Given this list of marker genes KIAA1958, AFDN, CREBRF (CREB3 regulatory factor), BMP3, RBMS1, CFTR, SEMA3A, PEX5L, MAP1B, NFIB, GPR12, SLC30A7, CACNA1C, TUBB1, SLC26A3, RAD23B, RAB27B, SEC24A, ANKMY2, RAB3C, MSI2, ZC3H6, ZFHX3, PROS1 (NCBI Gene Id 5627), PNISR, MGAT4A, TACC2, AKAP17A, SHMT1, MED1, SGIP1, TENM1, MYCT1, TMCC2, CDKL2, CSE1L, URI1, SLC1A2, TBCA, PCDH10, CEP120, CXXC4, KIAA2013, TNPO3 (NCBI Gene Id 404679), SYDE2, SLC17A7, CPLX3 (NCBI Gene Id 594855), BRCA2, DPM1, USP51, TNFSF10 (TNF superfamily member 10), CA10, MZT1, C21orf91, UBE2L6 (NCBI Gene Id 9246), TMEM154, LIN54, UTP15, SYT16, CEP170, PAG1, LATS2, VCPIP1, BCL7B, RAB23, OSR2, ASXL3, U2SURP, SP100, ZNF711, ZBTB21, USP24, TAF4B, FZD3, ABI3BP, CFHR3, CEBPZOS (NCBI Gene Id 105374463), TCF21, CHL1, CRIPT, SRP72, CELF1, TRAF3, CEP97, TOR1AIP2, DENND6A, SENP3, MEIS2, TRIM15, TUT7, SCG3, RUBCNL, SPOPL, SGMS1, RABEP1, SNAP91, EEF2K (NCBI Gene Id 29904), RPS6KA6, DNAJC6, ZYG11B, ZDHHC21, WDR26, PCDH19, NAV1, ELL2 (elongation factor for RNA polymerase II 2), CPT1A, UBE2B, SMN2, SMAD1, ZNF772, PIM1, FBXW11, RAPGEF5, C17orf100, MAF, SNW1, PPP1R9A, TRHDE, PDIK1L, ANKRD40, ABHD18, CXCR5 (NCBI Gene Id 643), STXBP5L, TLR6, SLC22A17, DSG2, ONECUT2, NAV3, PRRC2B, ITPR1, HLA-DQA1, WDR35, ENOPH1, RBM47, LMAN2, APBB2, PLOD2, SEPTIN9, SCAI, CSRNP3, PTPN4, CCDC82, DPYSL2, LAMC2, MBNL3, AAK1, GPATCH2L, ANKRD22, C3orf70, MIER3, ASB7, C7orf57, PTP4A1, NMNAT2, ZNF280C, SERPINE1, SEC62, FOXN2, KIF13A, TMTC3, VGLL3, STRIP2, VWC2, PELI1, PDS5A, ZFHX4, KIF4A, EFNB2, SLC4A4, ARF6, CADM1, MET, KPNA6, TIA1, RIF1, POU4F1, MED14, CAV2, PHACTR2, PPM1E, SEC63, RABGAP1L, LRCH2, CHD9, RBMS3, DDX3X, CLTA, MBNL2 (muscleblind like splicing regulator 2), ESM1, DYNC1I1, KALRN, TMEM59, MATR3, FAM169A, WDR48, MCTS1, GNPNAT1, PDX1, NCOA2, TTC39C, ARHGAP6, PLSCR5, EPHA3, ELF2, TMEM26 (transmembrane protein 26, NCBI Gene Id 219623), PAXBP1, APC, CCT4, BBOX1, EIF5, ZNF148, RB1, SLC35F1, ABCC12, NPL, CNOT6, EPHA5, STAM, CREB1, AGO4, RPS6KB1, SAMTOR, PHC3, KCNAB1, LCOR, GATA3, LHFPL3, RB1CC1, DCUN1D1, SLC46A3, JAKMIP2, SRD5A2, ZBTB20, XRN1 (5'-3' exoribonuclease 1), NRP1, ZMYM3, PRKACB, PPP1CC, PPARGC1A, ZNF652, BCL2L11, HDAC9, NEXMIF, MAP3K1, OLFML1, DCBLD2, CYSTM1, SREK1, SLC16A12, CALCB, TMEM132B, LGALSL, MAPK9, CCNG2, RORA, C15orf40, OLFM3, KIF18A, RBM42, LRRC4C, KDM4C, CH25H, NMT2, CLDN11, LRRTM3, SOCS6, KIF3A, MORF4L2, XIAP, CLINT1, TMOD1 (tropomodulin 1), EML6, TPR, ERBIN, PANK1, FHOD3, ELOVL7, MAB21L1, PCDH15, PIANP, FAM135A, BMP2K, NAP1L2, FTSJ1, THSD7A, PHYHIPL, ADCY7, ANO5, IKZF2, SASS6 (SAS-6 centriolar assembly protein), TRAPPC13, CEP41, B3GALT2, EME1, PCDH9, BLCAP, EMX2, ANGPTL5, CACNB4, RUFY2, DTNA, KMT5B, ZNF287, BBX, PIK3CA, UBASH3B, CDK6, SIRT1, TMEM51, KLHL24, RASGRF2, ETV1, TENT5D, FLRT3, TSEN34, AMMECR1, ZNF704, NMI, MDGA2, TEX30, IMPA1, RBM18, RAPH1, NXPH2, CLU, ATP6V1C1, CHMP5, ATP8A2, ZNF816-ZNF321P, BCKDHB, FREM2, SMN1, YY1 (YY1 transcription factor), GIPC2, CUL3 (NCBI Gene Id 8452), SCYL2, FMR1, PRKAA2, ZNF333, NEK10, EXD2, RTKN2, CFHR4, TNFSF13B, SPAG6, CLIC5, GANC, RPS6KA3, PDCL3, CADM2, PPP4R4, RFX6, PPP4R2, GPR180, SS18, KRT10-AS1, BCLAF1, EPS15, BCL7A, SENP7, CRISPLD1, ENPEP, MFSD8, FNIP2, DHX40, CCDC85C, S1PR1, DCLK1, TMEM255A, KCNJ13, KHDRBS1, KLF8, MBNL1, MYL6B, SORCS3, C2orf49, here is a description of the gene set: from publication Chen Y, Wang X (PMID 31504780) species: Homo sapiens Human Gene Set: MIR510_3P Genes predicted to be targets of miRBase v22 microRNA hsa-miR-510-3p in miRDB v6.0 with MirTarget v4 prediction scores > 80 (high confidence targets).